The following is a description of a gene set: Human Gene Set: REACTOME_CELL_CYCLE_CHECKPOINTS Cell Cycle Checkpoints studied in species Homo sapiens, and this is the list of marker genes: NUP85, PSMA6, PSMC1, H2BC21, BUB3, BARD1, PSMD7, CDC6, H4C14, SEM1, PPP2R1B, CCNE1, YWHAB, MRE11, CENPF, H2BC4, DYNLL2 (dynein light chain LC8-type 2), CENPP, PSMA4, RANBP2, NBN, H4C12, NSD2, DBF4, ORC3, NUP43, ANAPC2, RAD9A, MCM3, CCNB1, H2BC13, CDC16, YWHAG, NUP133, CDC26, ANAPC10, ZNF385A, RPS27A, SEH1L, SKA2, COP1, CLASP1, NUP37, KIF2B, KIF2C, RFC3, ANAPC5, NUP98, UBE2C, CDKN1B, H4C2, CHEK2, PSMA1, H2BC11, CDC45, MAPRE1, PSMB3, ZWINT, UBE2E1, BRCA1 (NCBI Gene Id 672), MCM2, ORC5, HERC2, RPA1, RPA3, RBBP8, PSMB5, UBA52, KAT5, H2BC8, RPA2, PPP2CB, CDC25C, SEC13, CDCA8, ORC4, MDC1, KNTC1, UBE2N, H4C16, TOPBP1, PSMA2, AURKB, RAD17, XPO1, PPP2R5B, PSMA7, SGO2, PSMA5, PSMD2, CENPC, H2BC9, H4C15, ZW10, H4C1, BLM (NCBI Gene Id 641), CENPE, PHF20, H2BC10, DYNC1I2, UBB, NDC80, PSMB7, DYNC1LI1, PSMD14, CENPA, MDM4, ANAPC1, DYNC1I1, PPP2R5D (NCBI Gene Id 5528), H2BC6, CDC27, UBC, RAD1, MAD2L1, PKMYT1, CCNE2, AHCTF1, H4C11, MCM6, H2BC3, CENPT, RCC2, NDEL1, SPDL1, ANAPC7, H4C13, DNA2, PLK1, UBE2S, ORC2, CCNB2, MCM10, ADRM1, BABAM2, CDKN2A, MCM4, CDC23, H4C6, CDC25A, PSMC6, MCM7, ORC6, PAFAH1B1, NUDC, CDK1, CHEK1, BUB1B, H2BC14, H2BC5, CENPH, H2BC1, PSMC3, KIF2A, H2BC12, MDM2, MIS12, ZWILCH, RFC2, PCBP4, CENPO, CDKN1A, SPC24, ANAPC11, PPP2R5E, CDC20, H2AX, PPP2R5C, PSMD3, H4C5, RHNO1, ORC1, H4C4, HUS1, BUB1, BRCC3, YWHAQ, PSMA3, ATRIP, SKA1, KNL1, RMI1, RNF8, PSMB4, PSMC4, DSN1, NSL1 (NCBI Gene Id 96380), PSMD13, MCM5, CLSPN, H4C3, NUP107, DYNC1LI2, BABAM1, PSMC2, CENPI, PPP2R1A, ATM, UBE2V2, GTSE1, CENPN, H2BC12L, RNF168 (NCBI Gene Id 165918), H3-4, ABRAXAS1, CENPS, PIAS4, KIF18A (NCBI Gene Id 81930), PSMB2, ANAPC16, TOP3A, BIRC5, CDC7, SFN, H4C8, PSMD11, H4C9, CENPM, RMI2, PSMD12, RAD50, EXO1, CENPQ, CCNA2, RFC5, CKAP5, H2BC26, H2BC15, RANGAP1, CENPU, CCNA1 (cyclin A1), YWHAE, UBE2D1, CLASP2, ATR, H2BC17, NUP160, ANAPC15, YWHAH, RFC4, H2BC7, SGO1, PSMD1, TP53BP1, MCM8, MAD1L1 (mitotic arrest deficient 1 like 1), CENPK, WRN, DYNC1H1, CLIP1, PPP2R5A, PMF1, INCENP, UIMC1, DYNLL1, ERCC6L, CENPL, BRIP1, TP53, NDE1, PPP1CC, PSMD8, NUF2, CDK2, RPS27, PSMB6, ITGB3BP, RAD9B, PSMC5, PSMD6, PSMB1, PPP2CA, WEE1 (NCBI Gene Id 7465), ANAPC4, TAOK1 (NCBI Gene Id 80214, TAO kinase 1), SPC25, B9D2, YWHAZ